The following is a description of a gene set: Any process by which the number of skeletal muscle satellite cells in a skeletal muscle is maintained during muscle regeneration. There are at least three mechanisms by which this is achieved. Skeletal muscle satellite stem cell asymmetric division ensures satellite stem cell numbers are kept constant. Symmetric division of these cells amplifies the number of skeletal muscle satellite stem cells. Some adult skeletal muscle myoblasts (descendants of activated satellite cells) can develop back into quiescent satellite cells, replenishing the overall pool of satellite cells. studied in species Homo sapiens Human Gene Set: GOBP_SKELETAL_MUSCLE_SATELLITE_CELL_MAINTENANCE_INVOLVED_IN_SKELETAL_MUSCLE_REGENERATION, and this is the list of marker genes: WNT7A, FZD7, EZH2, IGF1, SELENON